The following is a description of a gene set: Mouse Gene Set: GOMF_PHOTORECEPTOR_ACTIVITY The function of absorbing and responding to incidental electromagnetic radiation, particularly visible light. The response may involve a change in conformation. studied in species Mus musculus, and this is the list of marker genes: Rrh, Opn1mw, Gpr88, Cry2, Opn3, Opn1sw, Opn5, Cry1, Gpr52, Rgr, Opn4, Rho